The following is a description of a gene set: Catalysis of the reaction: O-phospho-L-seryl- + H2O = L-seryl- + phosphate. studied in species Mus musculus Mouse Gene Set: GOMF_PYRUVATE_DEHYDROGENASE_ACETYL_TRANSFERRING_PHOSPHATASE_ACTIVITY, and this is the list of marker genes: Ppm1m, Ppm1j, Pdp1, Pdp2, Ppm1h